Given this list of marker genes HMSD, DLGAP4, ETV3, ISG20, MAP3K14, CCR7, RFTN1, DUSP4, CCL19, PLAAT3, POLD1, ADORA2A, IL4I1, DUSP5 (dual specificity phosphatase 5), LINC01857, ZEB1, GADD45A, SLC44A1, VAC14, SLCO5A1, DAAM1, UBD, EDARADD, NECTIN2, AOC1, CEP15, HLA-DQB2, DSG2, BTN2A2, TMCC3, C17orf49, SOCS1, TRAF1, FBXO27, RAB30 (RAB30, member RAS oncogene family), SNX11, MMD, P2RY8, CLIC2, GBP4, TSPAN33, A1BG, ATP6V0A2, IL7R, NIBAN1, DCAF6, SBNO2, ZNF296, IRF4, ANKRD33B, LRRFIP2, FOXD4L3, ARHGAP10, H6PD, IDO1, CKB, ABCC4, DHX58, ATP8A1, LAMP3, SAMD9L, CASTOR1, TRAFD1, RASGRP3, CD40, BCL2L14, FLT3, ARL17B, GNG11, ICAM4, LZTFL1, PLEKHG1, APOBEC3H, LINC01588 (long intergenic non-protein coding RNA 1588), ZNF608, COMTD1, THAP2, LY75, ENOX1, NET1, FAS, ANTXR2, POGLUT1, ETV3L, ALCAM, RNF19B, ENO3, PPP1R16B, PSD3, RHOF, ANKRD55, EBI3, NMRK1, ZNF366, TFPI2, GPR137B, NUAK2, CCDC28B, CD80, TVP23A, CCL22, MIR155HG, CCDC81, CEP135, CHD3, MAP1LC3A, JAG1, CYB5A, TRADD, IL15, TMEM176A, GPR157, TBC1D8, FOXD4L4, HLA-DOB (NCBI Gene Id 3112), PSEN2, SLC22A23, GBP1, ACHE, P2RY10, LRRC61, HDHD3, LIMCH1, TRAF5, ARHGAP22, TREML1, CD274, BCL2L11, PLXNC1, PHLDA2, TSPAN15, IL32, TRIP10, CHST7, RAB5B, TNIP2, ZC3H7B, TRABD2A, MGLL, BIRC3, LUZP1, NCCRP1, MREG, MAP4, SNN, CASP7, NDE1, EPSTI1, MMP2-AS1, HLA-F, AUTS2, MACROH2A2, CD1E, CXCL10, TMEM176B, GCSAM, WNT5B, CXCL9, MYO1C, CD200, TUBB6, SPIB, HOPX, RASGRF1, TNFRSF8 (NCBI Gene Id 943), NRP2, TBC1D4, IGKC, ICOSLG, TSPAN13, ADAM19, LAD1, here is a description of the gene set: from publication He P, Lim K, Sun D, Pett JP, Jeng Q, Polanski K, Dong Z, Bolt L, Richardson L, Mamanova L, Dabrowska M, Wilbrey-Clark A, Madissoon E, Tuong ZK, Dann E, Suo C, Goh I, Yoshida M, Nikolić MZ, Janes SM, He X, Barker RA, Teichmann SA, Marioni JC, Meyer KB, Rawlins EL (PMID 36493756) Human Gene Set: HE_LIM_SUN_FETAL_LUNG_C2_ADC_1_CELL species: Homo sapiens aDC 1